The following is a description of a gene set: species: Homo sapiens Genes having at least one occurrence of the motif NNNTNNNGNGTGANN in the regions spanning 4 kb centered on their transcription starting sites. This matches the PAX8 transcription factor binding site V$PAX8_01 (v7.4 TRANSFAC). Human Gene Set: PAX8_01, and this is the list of marker genes: TRIB1, LRRC74A, SMC4, IKZF5, LMO3, DMD, CCDC24, JMJD1C, RERG, TCF7L2, LUC7L3, NKX2-8, IFT80, UBE2N, NOL4, TMEM255A, OLFM2, NABP2, TAF5, GGN, HOXD12, BHLHE22, MAB21L2, AHCYL1, ACADSB, IKZF2, MAN1C1, KCND3, ACTN1 (NCBI Gene Id 87), PUM2, DLEU1, HR, CAMK1D, DLEU2, SUPT16H, PCDH7 (NCBI Gene Id 90855), CITED2, ARB2A, OSBPL7